The following is a description of a gene set: Genes up-regulated in comparison of control dendritic cells (DC) at 4 h versus those stimulated with CpG DNA (TLR9 agonist) at 4 h. species: Homo sapiens from publication Amit I, Garber M, Chevrier N, Leite AP, Donner Y, Eisenhaure T, Guttman M, Grenier JK, Li W, Zuk O, Schubert LA, Birditt B, Shay T, Goren A, Zhang X, Smith Z, Deering R, McDonald RC, Cabili M, Bernstein BE, Rinn JL, Meissner A, Root DE, Hacohen N, Regev A (PMID 19729616) mouse primary BMDCs were stimulated with tlr ligands and gene expression changes were profiled on Affymetrix arrays Human Gene Set: GSE17721_CTRL_VS_CPG_4H_BMDC_UP, and this is the list of marker genes: DCPS, BCAP31, CEP250, POLR2B, CCNG1, SFXN3, MGAT2, SLC30A5, BDH1, CTPS1, VDAC1, NUP43, ELF3, FASTKD1, AP5M1, BLCAP, ACADVL, AUH, ATP6V1F (NCBI Gene Id 9296), MYT1 (myelin transcription factor 1), TIAM1, ARAF, ZKSCAN3, TXNDC5, TMEM51, CTR9, ACADS, AIFM1, TADA1, C19orf48P, SLC26A6, F7, RPA1, SLC25A4, GAS2, MAP2K4, TSPAN14, CIB2, ARC, LHX6, TNFRSF21, KHK, SLC29A3, ZNF287, MATR3, RFC1, DMAC1, COA6, CROT, SERINC3, LANCL1, PHPT1, ELP2, PLEKHA1, LSM4, TMEM147, SLC35A5, PLEKHG2, PTMS, TOMM22, VOPP1, KIF1C, RALBP1, MLYCD, STOML2, MAPK3, POGLUT2, KCNK13, RASSF2 (NCBI Gene Id 9770), RPA2, SLC25A3, RABEPK, LXN, NCOR2, MRPL44, TF, XPR1, SELENBP1, ABCF1, TECR (trans-2,3-enoyl-CoA reductase), CDIP1, RTN3, ADH5, C1orf54, GPR146, NELFA, XBP1, QRSL1, CPT1A, RD3, ADNP, NUDT3, MKNK2, KANSL2, TUBA1B, OPN1SW, ECHDC1, IFI30, DOK3, TUBGCP2, DNAJB1, FAM76A, MIDN, IQGAP3, GPS1, PEF1, PCBD1, RAP1A, TM2D3, GAB3, TEC, XPOT, KRTAP4-11, ACAT1, PLPP2, RNF181, MEPCE, ATM, NSMCE4A, NDUFA4, MRAS, RPL38, KLRD1, GPN3, SLAMF9, ALDH3A2, SLC7A7, ZBTB25, PIK3CG, GUSB, PLIN3 (NCBI Gene Id 10226), ICE2, NAGK, HMBS, ERMP1, RPS8, RFX1, GASK1B, ZNF703, FBLIM1, KCNJ10, DUSP19, PIP4K2A, PHETA2, CDC42SE1, CDC23, RTCB, NPC2, GCNT1, ZFAND1 (zinc finger AN1-type containing 1), SLC25A46, MRPL51, RNASE4, ACOT1, CDK1, PEPD, HEXIM1, VAC14, MRPS25, SMARCA4, TRIM32, PNRC1, IMPACT, PLSCR3, ARMC7, ZNRD2, OSBP, TRPT1, UBR7, PTDSS1, CIDEB, TMEM14C, GADD45GIP1, SPEG, IDH3A, ZNF574, DIP2B, EIF3B (eukaryotic translation initiation factor 3 subunit B, NCBI Gene Id 8662), MSL1, USP1, UNC119B, CCNB2, SMC3, GIT1, EPS15, PSRC1, LCMT1, FRMD8, HACL1, TNNC1, PTOV1, POLE3, STRBP, TGFBI, C19orf53 (NCBI Gene Id 28974), SMPD2, UBXN11, HLA-DMA, SYNPO, AMACR